Given this list of marker genes KHDRBS3, KHDRBS2, KHDRBS1, SFPQ, PTK6, here is a description of the gene set: PTK6 binds and phosphorylates several nuclear RNA-binding proteins, including SAM68 family members (KHDRSB1, KHDRSB2 and KHDRSB3) and SFPQ (PSF). The biological role of PTK6 in RNA processing is not known. part of: Signaling by PTK6 studied in species Homo sapiens Reactome Pathway: PTK6 Regulates Proteins Involved in RNA Processing